The following is a description of a gene set: species: Homo sapiens from publication Sanda C, Weitzel P, Tsukahara T, Schaley J, Edenberg HJ, Stephens MA, McClintick JN, Blatt LM, Li L, Brodsky L, Taylor MW (PMID 16800785) Type I and type II interferons (IFNs) bind to different cell surface receptors but activate overlapping signal transduction pathways. We examined the effects of a type I IFN (IFN-acon1) and a type II iFN (IFN-g1b) on gene experession in A549 cells and demonstrate that there is a common set of genes modulated by both IFNs as well as a set of gene specifically regulated by each, reflecting the activation of different signaling pathways. In particualr, IFN-g induced many more genes of the signaling pathways, apoptosis, and cytokine interactions than did IFN-a. Even with genes induced by both IFNs there were distinctive quantitativive differences in expression. IFN-g1b plays a major role in the induction and regulation of the complement pathway. Previous work has shown a synergistic antivral and antiproliferative effect of type I and type II IFNs in cell culture and in the treament of tumors in mice. We demonstrate that a majority of genes showed and additive effect of IFN-acon1 and IFN-g1b, but a subset of gene is synergistically induced; these incluce ISG10, MX2, OAS2, and other genes known to be involved in the antiviral response, TRAIL (TNFSF10) and caspases involved in apoptosis and chemokine genes RANTES, CXCL10, and CXCL11. Greater than additive transcription of some of these genes in the presence of both IFNs was confirmed by real-time kinetic RT-PCR. Elevated induction of many of these genes may be sufficient to explain the synergistic antiviral and antitumor effects of this combination of IFNS in vivo. Genes down-regulated in epithelial cells (6h): untreated versus interferon alpha and IFNG. Human Gene Set: GSE5542_UNTREATED_VS_IFNA_AND_IFNG_TREATED_EPITHELIAL_CELLS_6H_DN, and this is the list of marker genes: ABI3 (NCBI Gene Id 51225), NEDD9, NRG2, DCAF15, PLEKHF1, ELF3, SLC4A4, MBD6 (NCBI Gene Id 114785), DCBLD1, NHLRC2, MYBL1, NR2C2, TNFRSF1A, TCIRG1, ACADVL, SLC2A4, FKBP11, N4BP1, RHOC, APOBEC3G (apolipoprotein B mRNA editing enzyme catalytic subunit 3G), SLC25A22, KLHL17, RBMS3, IFI6, MAN1A1, ZFYVE28, ZNF219 (zinc finger protein 219), SRF, TBXAS1, NFAT5, MYO5A (myosin VA), CACNA2D2, ATG2A, PTPN1, ITGAV, MAF, PLEKHA5, SOX13, TRAF6, SASH3, PPP4R1, ATP2A3, LZTR1, CTSD, EIF4EBP2, ACTN4, ZDHHC7, ADAM10, DENND1B, B4GALT5, ARHGAP35, CNNM3, FCHO2, NINJ2-AS1, PIK3AP1, AGAP2, MIR199A1, CD58, AGO4, ZCCHC12, ATOSB, SLC25A43, S1PR5, ST3GAL4, MRGBP, ODAD4, KLC2, TMX4, SP140, MAPKAPK2, MXD4, NAA38, LCP2, MPP1, SIGLEC14, SPEF2, ADCY9, ULBP3, THBS1, NCALD, P2RX7, FOXO3, YWHAH, STAT4, ARNT, ARHGAP10, RALGPS1, EFCAB14, MNX1, CBX6, TACC1, CXCR6, LIMK1, SLC23A2, ASCL2, HEG1, CPEB3, MYH9, SPN, FAM199X, SCARNA17, CFLAR, CCDC142, GYG1, CHD9, TACR1, MXRA7, CKM, CCDC12, PTPRM, CAMK1D, DENND1A, ATP10D, RCVRN, PPP2R5E, CAMK2N1 (NCBI Gene Id 55450), ARPC5L, MESD, SIK2, B3GALT4, FAM131B, ZNF41, KLRF1, KATNB1, AUTS2, MAP3K5, ZBTB44, HEATR5A, RBMXL3, NF1, PHLDB2, NCBP3, TNFSF14, ZNF474, LGI3, CMIP, FOCAD, KLF13, SP2, TBC1D31, PARP8, UEVLD, TRIM14, MBD2, TGFB3, E2F4, BRCA1, GAB3, UBE2I, ITPRIP, FYCO1, RASAL3, DLG5, PIK3CG, MBNL2, EVI5L, SLC6A6 (NCBI Gene Id 6533), PTPN22 (NCBI Gene Id 5779), TBC1D2B, CDC42EP3, DNAJC8, MBNL3, CYTH3, ERMP1, CD99L2, KCNAB1, B3GLCT, PRKCE, CLSTN3, C3AR1, PIP4K2A, DTD1, TMEFF1, NPC1, WDR5CP, CRADD, ASB6, MDGA1, ZFYVE21, GFI1, OSBPL7, GFPT2, GALNT3, RC3H1, EGR3, PTK2B, BMPR1A, FUT4, RAD54L2, ABCA2, BHLHE40, TCF7L2, NOD1, PTPRE (protein tyrosine phosphatase receptor type E), GLCCI1, ZNF16, AGTRAP, TCF12, PLXND1, LATS2